Given this list of marker genes INPP5E, RPGRIP1L, TMEM216, AHI1, CEP290, here is a description of the gene set: Neonatal breathing dysregulation studied in species Homo sapiens Human Gene Set: HP_NEONATAL_BREATHING_DYSREGULATION